The following is a description of a gene set: Genes selectively expressed by intermediate progenitor cells (basal subtype) in embryonic day 14.5 mouse cortex. Mouse Gene Set: HEVNER_CORTEX_BASAL_INTERMEDIATE_PROGENITOR_CELLS studied in species Mus musculus from publication Bedogni F, Hevner RF (PMID 34321999), and this is the list of marker genes: Chga, Rnasel, Sema3c, 9630028B13Rik, Scrt2, Ccdc88c, Bcar1, Rnd3, Ddit4, Grik2, Rwdd3, Serping1 (serine (or cysteine) peptidase inhibitor, clade G, member 1), Fam110a, Clvs1, Mfap4, Plekhf2 (NCBI Gene Id 93778), Pam, Cdh8, Neurod1, Abcd4, A330008L17Rik, Dubr (Dppa2 upstream binding RNA), Sstr2, Vat1, Arhgef25, Hs3st1, Kif21b, Trak2, Lpin1, Trp53inp1 (NCBI Gene Id 72576), Nrp2, Shisa2 (NCBI Gene Id 320778), Plcb1, Slc30a10, Pcdh7, Chn2 (NCBI Gene Id 74804), Ranbp9, Ppp2r3c, Lrrn3, Kcnd2, Igsf21, Sh3bgrl2, Jarid2, Plxna2, Dusp4, Nptx1, Sorbs2 (sorbin and SH3 domain containing 2), Slc17a6, Dipk2a, Unc5d, Sesn1, Nrn1, Dok4, Nhlh1, Kif26b, A930024E05Rik, Ddhd1, Carmil3, Prex1, AI504432, Myt1, Cckar, Dusp14, Mgat5b, Pde1c, Virma, Fgf11, Dll3